Given this list of marker genes PAK2, RIN2, DOHH, KAT5, SLC39A5, GPR179, CNGB3, COX7B, PAX2, TTC8, FBXO11, CRIPT, TBC1D24, IPO8, SCO2, TTR, HCCS, RP2, ADAMTS10, TTLL5, MYOC, ASXL1, BAP1, ADAMTSL4, EXOSC2, COL2A1, GLRA2, ZNF408, COL9A1, B4GALT1, FBN1, RPGR, ZNF644, SLITRK6 (SLIT and NTRK like family member 6), HS6ST2, COL11A2, HERC1, PRIMPOL, LTBP2, DAG1, IRX5, COL18A1, ATP6V1A, ADAMTS17, PRDM5, PNPLA6, POMGNT1, EFL1, POLR3B, ELOVL4, ACBD6, COL9A2, CPSF1, CCNQ, PPOX, LOXL3, EFEMP1, BMP4, GZF1, NYX, TGFBI, LRPAP1, ATP6V1E1, MAF, CRYAB (crystallin alpha B), LRP2, COL11A1, NFIX, RAB28, ZFX, CYP1B1, SMS, MFSD8, NDP, P4HA2, ZNF469, ERBB3, CYP4V2, NDUFB11, VPS50, COL9A3 (NCBI Gene Id 1299), P3H2, LAMB2, POC1B, ASPH, FGFR3, LRIT3, FZD5, RPL10, PDE6H, ARR3, NMNAT1, ATP6V0A2, RECQL4, MANF, BLOC1S3, DPH5, here is a description of the gene set: A severe form of myopia with greater than -6.00 diopters. Human Gene Set: HP_HIGH_MYOPIA High myopia studied in species Homo sapiens